Given this list of marker genes PROM1, GRB10 (NCBI Gene Id 9769), TNFRSF1A, B3GNTL1, GSS, LILRA2, MATK, ZNF423, PSMG1, H4C13, AIF1, ATP2B4, DMXL2, CDK1, LILRB2, PFN2, CAV1, DUT, CD34, TUBA4A, AGPS, HEXB, NPY, FKBP4, HOXA9, ATIC, NET1, CLEC11A, PLSCR1, FHL1, GNAQ, RETREG1, GBP1, MYLK, FOXM1, SLC31A1, GUCY1A1, ARHGEF17, ERG, IFT25, BID, MPDU1, UMPS, SYNGR1, CENPF, ANXA4, VCL, SRRD, CKS1B, IARS1, SPINK2, HSPB1, TRAP1, PDS5A, AMOT, MEF2C, ERG28, AQP2 (aquaporin 2), GAB2, CACNB3, STARD3, RCN1, ATP1A3, KBTBD11, RPP40, CKS2, DYRK3 (dual specificity tyrosine phosphorylation regulated kinase 3), HS2ST1, ATP6V0E2, UBE2C, POLE2, EDEM1, CD27, ADCY3, GINS1, KIF23, TK1, LAPTM4B, CYFIP1, KIF2C, FBLN5, PRNP, FRMD4B, H2AX, LCP2, CKMT2, THEMIS2, FOXO3, COBL, PFKM, EHBP1, NAE1, SEC63, HPRT1, NUDT1, LDHA, FLT3, STK3, PTGER2, GART (phosphoribosylglycinamide formyltransferase, phosphoribosylglycinamide synthetase, phosphoribosylaminoimidazole synthetase), TNFSF4, MTHFD1, TJP2, MT2A, SLC25A12, RFC4, GLDC, NCAPH, HLTF, ETFB, CERS6, CCNA2, DST (dystonin), NR3C1, FANCL, RGL1, PAICS, CHEK1, TRIP13, TXN, LMO2, PECAM1, SCHIP1, STT3A, CIT, TSPAN7, SV2A, TCIRG1, MACF1, SALL2 (NCBI Gene Id 6297), ACSL1, TRAF3IP2, KIF11, FHIT, MACIR, SLC2A5, NAB1, SORL1, SERPINB6, HOXA10, LST1, HIVEP2, SERINC5, SERPINI1, NDN, MLLT11, RAB13 (NCBI Gene Id 89672), ALDH7A1, TRIP6, EBP, ABLIM1, PLXND1, KDSR, GMPS, CYRIA, GYPC, PGRMC1, MAP4K4, NEDD4, MPHOSPH6, MTHFD2, TMEM106C, ST3GAL6, CSE1L, ADGRA3, SIGMAR1, CCND2, SOCS2, BMI1, GALE, ACTN1, IGFBP7, GGH, FANCG, MDFIC, NME1, CD99, PLCB1, ZNF248, PRPSAP1, POLE, PAPSS1, SCML2, NID2, IMPDH2, TTK, GNG11, GRB14, PLXNB2, IMPDH1, TRIM14, PPT1, KCNS3, CD96, BCAT1, CYP1B1, ARRB2, PSD3, AP3S1 (adaptor related protein complex 3 subunit sigma 1), LGALS3BP, here is a description of the gene set: The injection of the pathogen-associated molecular pattern Polyinosinic-polycytidylic acid (poly(I:C)) leads to the activation of various immune cells, including dendritic cells (DCs) and Natural Killer (NK) cells. This activation is due to different innate cytokines produced early after injection, in particular IFN-I. The objective of the study was to compare the pattern of expression of IFN-I stimulated genes between DC and NK cells. The project focused on a specific subset of conventional DC, CD8a DC, which responsiveness to IFN-I determines the capacity to activate CD8 T cells by cross-presentation of exogenous antigens. To identify the responses to IFN-I selectively induced in CD8a+ DC, we compared their gene expression profile to that of NK cells, using gene chips, before and after poly(I:C) stimulation. species: Homo sapiens Human Gene Set: GSE39556_CD8A_DC_VS_NK_CELL_UP Genes up-regulated in CD8A dendritic cells versus NK cells. from publication Baranek T, Manh TP, Alexandre Y, Maqbool MA, Cabeza JZ, Tomasello E, Crozat K, Bessou G, Zucchini N, Robbins SH, Vivier E, Kalinke U, Ferrier P, Dalod M (PMID 23084923)